The following is a description of a gene set: studied in species Homo sapiens Human Gene Set: GOBP_REGULATION_OF_HEMATOPOIETIC_PROGENITOR_CELL_DIFFERENTIATION Any process that modulates the frequency, rate or extent of hematopoietic progenitor cell differentiation., and this is the list of marker genes: FLCN, SOS2, RARA, SPI1, DHX36, NUDT21, PCID2 (PCI domain containing 2), ANKLE1, TMSB4X, EIF2AK2, FNIP1, N4BP2L2, METTL3, MYB, PDCD2, SETD1A, VEGFA, NOTCH1, CDK6, KITLG, METTL14, HMGB1 (high mobility group box 1), OSM, HES5, MIXL1, SOS1, HES1, GATA2, PUS7 (pseudouridine synthase 7), PRKDC, FOXC1, NFE2L2, YTHDF2, KDR, ITCH, ABL1, HSPA9, ZNHIT1, KAT5, DPF2, TCF15, ZBTB1